The following is a description of a gene set: A protein complex that consists of members of the Bcl-2 family of anti- and proapoptotic regulators. Bcl-2 proteins respond to cues from various forms of intracellular stress, such as DNA damage or cytokine deprivation, and interact with opposing family members to determine whether or not the caspase proteolytic cascade should be unleashed. Human Gene Set: GOCC_BCL_2_FAMILY_PROTEIN_COMPLEX species: Homo sapiens, and this is the list of marker genes: BIK, BCL2, PMAIP1, BAK1, BAX, BCL2L11, BCL2L1, BAD, BCL2L2, MCL1